The following is a description of a gene set: Genes predicted to be targets of miRBase v22 microRNA hsa-miR-2861 in miRDB v6.0 with MirTarget v4 prediction scores > 80 (high confidence targets). Human Gene Set: MIR2861 from publication Chen Y, Wang X (PMID 31504780) studied in species Homo sapiens, and this is the list of marker genes: RDH12, PCDHGA6, BSDC1, PCDHGB7, E2F2, PCDHGA1, PCDHGB2, INTS6, XIRP1 (NCBI Gene Id 191580), PCDHGA5, MARK2, SEMA4G, CEACAM19, CHTF8, INF2, PCDHGB6, PCDHGA8, ESYT1, RIMS4, PCDHGC4, WASF2, ZNF33A, YKT6, ARHGDIA (NCBI Gene Id 396), SMPD3, EPS8L2, FIBCD1, TMEM120B, POLR2J3, MTHFD1, PCDHGA2, MGLL, MYO1D, P2RX5, C15orf40, SHISA9 (shisa family member 9), SPRYD3, ELAVL3, PCDHGA11, PCDHGA3, MAGEA11, MTSS2, BMP1, CHD5, POLR2J2, PCDHGA10 (protocadherin gamma subfamily A, 10), HOXC6, PPP1R10, IRAG1, FAM131B, ZNF33B, CCSER2, MBL2, PCDHGB1 (protocadherin gamma subfamily B, 1), PCDHGC5, SPATA13, PSD2, SSPN (sarcospan), FYCO1, FOXN3, PCDHGA9, GRM4, ZFTA, SOCS3, EFHD2, FADS1, MOB1A, CAMKV, CNBP, STOML1, PCDHGB3, SYT12, PCDHGA7, USP19, PDK4, PRIMA1, PCDHGB4 (protocadherin gamma subfamily B, 4), PCDHGA4, PTPRD, ZNF276, PCDHGC3, PCDHGB5, PHF21A, ST3GAL3, KIF21B, PCDHGA12, SCNM1, NUP214, NEUROD2 (neuronal differentiation 2)